Given this list of marker genes F8, F10, F9, here is a description of the gene set: Factor IX (FIX) deficiency is associated with mild to severe bleeding in hemophilia B (HB) patients (Rallapalli PM et al. 2013). HB is caused by a wide range of mutations that can include point mutations (nonsense and missense), insertions, deletions and other complex rearrangements of the F9 gene (Rallapalli PM et al. 2013). 2015), G357E (Miyata T et al. 1991), A436V (Usharani P et al. 1985), I443T (Hamaguchi N et al. 1991), G409V (Bajaj SP et al. 1990), D410H and S411G (Ludwig M et al. 1992). Reactome Pathway: Defective F9 variant does not activate FX part of: Defective factor IX causes hemophilia B studied in species Homo sapiens